Given this list of marker genes H3c8, Irs2, Pik3r1, H3c15, H3c10, H3c13, Pik3r3, H3c4, H3c6, Tslp, Brwd1, Il7 (interleukin 7), Stat5a, H3c1, H3c3, Stat3, H3c2, Stat5b, Pik3r2, Smarca4, Il2rg, H3c7, H3c11, Il7r, H3c14, here is a description of the gene set: species: Mus musculus Mouse Gene Set: REACTOME_INTERLEUKIN_7_SIGNALING Interleukin-7 signaling